The following is a description of a gene set: Reactome Pathway: vRNA Synthesis The synthesis of full-length negative strand viral RNA from a cRNA template is believed to follow the same principles as the synthesis of cRNA from a vRNA template. The cRNA, complexed with viral nucleocapsid (NP) protein, is used as template by the trimeric viral polymerase, and newly synthesized vRNA molecules are immediately packaged with NP molecules to form ribonucleoprotein complexes. There is some evidence that the production of vRNA-containing vRNP occurs in the nuclear matrix as well as the nucleoplasm. studied in species Homo sapiens part of: Influenza Viral RNA Transcription and Replication, and this is the list of marker genes: PARP1, NP, PB1, PA, NS, PB2